The following is a description of a gene set: Mouse Gene Set: GOBP_CELLULAR_RESPONSE_TO_EPINEPHRINE_STIMULUS Any process that results in a change in state or activity of a cell (in terms of movement, secretion, enzyme production, gene expression, etc.) as a result of an epinephrine stimulus. Epinephrine is a catecholamine that has the formula C9H13NO3; it is secreted by the adrenal medulla to act as a hormone, and released by certain neurons to act as a neurotransmitter active in the central nervous system. species: Mus musculus, and this is the list of marker genes: Ryr2, Akap6, Slc9a1, Star, Kcnq1, Pde4d (phosphodiesterase 4D, cAMP specific), Nos1, Atp2b4, Adipoq, Sirt2